Given this list of marker genes OR4K17, OR52E1, OR2F2, OR51V1, OR56B4, OR8B8, OR5D13, OR8D1, OR13C7, OR2H1, OR2L13, OR2B11, OR52E8, OR5J2, OR2F1, OR11H7, OR1I1 (NCBI Gene Id 56657), OR52N5, OR8U1, OR5K3, OR4N2, OR1M1, OR8G1, OR4Q2, OR1D4, OR10R2 (NCBI Gene Id 79506), OR2A42, OR1B1, OR6C74, OR4F5, OR5A1, OR5F1, OR2T27, OR6B1, OR5K2, OR9I1, OR6B2, OR2G3, OR10V1, OR51D1, OR51A4, OR56A3, OR10Z1, OR6M1 (NCBI Gene Id 79548), OR2AG1, OR4A15, OR1F1, OR10AG1, OR2T29, OR14L1, OR2T10, OR52K2, OR1Q1, OR11H1, OR2T1, OR4X2, OR4D1, OR6C68, OR56B2P, OR8I2, OR10A2, OR1S2, OR6C1, OR8K1, OR2I1P, OR10W1, OR2AG2, OR10K1, OR10G6, OR8J3, OR4N5, OR5T3, OR1L6, OR4C45, OR4C5, OR10D3, OR8H3, OR51B4, OR5AS1, OR52N4, OR51L1, OR56B1, OR1S1, OR7D4, OR10G4, OR52N2, OR6N2, OR2AJ1, OR51G1 (olfactory receptor family 51 subfamily G member 1), OR2AE1, OR2T11, OR2A5, OR10J5, OR5A2, OR8B12, OR13C2, OR6J1, OR8A1 (olfactory receptor family 8 subfamily A member 1), OR4C12, OR4S1, OR6C65, OR4B1, OR5AR1, OR5M3, OR1K1, OR5V1, OR2T6, OR51M1, OR1J1, OR9Q2, OR14I1, OR11L1, OR5H2, OR2A12, OR1L4, OR6A2, OR4K15, OR4L1, OR4F3, OR10X1, OR7G2, OR3A1, OR8B4, OR10G2, OR5AP2, OR56A5, OR5K4, OR8H1, OR9G9, OR51I2 (olfactory receptor family 51 subfamily I member 2), OR4C15, OR5T2, OR51S1, OR10AD1, OR2M3, OR4A47, OR2AK2, OR4K14, OR10H3, OR4D10, OR5C1, OR11H6, OR13C6P, OR52K1, OR51A2, OR1A1, OR4M2B, OR1N1, OR9A4, OR9A1P, OR2G6, OR4A8, OR13C5, OR7G1, OR4K3 (olfactory receptor family 4 subfamily K member 3 (gene/pseudogene)), OR1D5, OR52B2, OR5L1, OR6V1, OR11H4, OR1E1, OR8B3, OR4C11, OR52J3 (olfactory receptor family 52 subfamily J member 3), OR13F1, OR2T12, OR1F2P, OR5AN1, OR7A2P, OR9G4, OR14J1, OR9A2, OR10K2, OR11H12, OR5L2, OR51B2, OR2B6, OR1E3, OR2B8P, OR2AT4, OR5W2, OR5H14, OR2J1, OR51B6, OR8J1, OR4F16, OR4D2, OR2L8, OR2T35, OR56A4, OR8G2P, OR6S1, OR8S1, OR14A16 (NCBI Gene Id 81455), OR10J6P, OR1J2, OR8K3, OR4A5, OR10A4, OR6C2, OR10D4P, OR5P2, OR51G2, OR1A2, OR2Z1, OR10S1, OR10G8, OR6K3, OR52A5 (NCBI Gene Id 390054), OR5M11, OR52L2P, OR10C1, OR2K2, OR5AU1, OR52M1, OR52A1, OR5H6, OR52W1, OR14A2, OR5M1, OR51F2, OR2C3, OR6K6, OR7C1, OR10Q1, OR4K13, OR5T1, OR52I2, OR1G1 (olfactory receptor family 1 subfamily G member 1), OR11G2, OR6N1, OR51A7, OR8H2, OR51H1, OR5AC1, OR51E1, OR8D4, OR2W1, OR4S2, OR2M2, OR6P1, OR2A25, OR52P1, OR51B5, OR4C46, OR2A4, OR4C6, OR5B2, OR2H2 (NCBI Gene Id 7932), OR4N4, OR6Y1, OR5D18, OR14K1, OR5B12, OR13C8, OR4C16 (olfactory receptor family 4 subfamily C member 16), OR6C70, OR5P3, OR2G2, OR52E5, OR1L8, OR5B3, OR51J1, OR7G3, OR2T8, OR10AC1, OR8U3, OR4D9, OR8D2, OR4K2, OR5M8, OR7A17, OR6C75, OR4D6 (olfactory receptor family 4 subfamily D member 6), OR5AK2, OR52H1 (olfactory receptor family 52 subfamily H member 1), OR2W3, OR2J3, OR8U9, OR52N1, OR10P1, OR3A3, OR10J4, OR2M4, OR51T1 (olfactory receptor family 51 subfamily T member 1), OR4F6 (NCBI Gene Id 81403), OR52D1, OR2W5P (olfactory receptor family 2 subfamily W member 5 pseudogene), OR13H1, OR56A1, OR2A7, OR2T3, OR4K5, OR7A5 (olfactory receptor family 7 subfamily A member 5), OR12D1, OR12D2, OR10J3, OR4P4, OR4F17, OR6C76, GPR148, OR7C2, OR4E2, OR5G3, OR10H2, OR52B6, OR6C3, OR4A4P, OR2L3, OR2T2, OR4F4, OR2W6P, OR5M10, OR1L1, OR6C4, OR2A14, OR3A2, OR4M1, OR2AP1, OR4D11, OR52E2, OR1D2, OR4M2, OR1N2, OR4F15, OR51Q1, OR5AC2, OR2V1, OR5H8, OR4C13, OR2D3, OR12D3, OR2J2, OR13D1, OR4D5, OR2T4, OR4F29, OR5B21, OR10A3, OR5B17, OR1F12P, OR9G1, OR8G5, OR1J4, OR13C9, OR6X1, OR2M5, OR2T33, OR7A10, OR51F1, OR9Q1, OR52I1, OR4A16, OR10A5, OR14C36, OR13C4, OR8K5, OR1C1, OR1P1, OR10A6, OR13A1, OR5BS1P, OR52L1, OR6K2 (NCBI Gene Id 81448), OR10H1, OR11A1, OR10H4, OR2L5, OR1L3, OR52E4, OR10T2, OR2C1, OR2A2 (NCBI Gene Id 81393), OR4E1, OR2B2, OR2S2, OR2D2, OR5I1, OR2A1, OR4C3, OR2B3, OR7D2, OR5M9, OR10H5, OR8B2, OR13C3, OR8U8, OR51E2, OR52R1, OR1E2, OR2T34, OR10G3 (olfactory receptor family 10 subfamily G member 3), OR2M7, OR6T1, OR10G9 (NCBI Gene Id 81351), OR6C6, OR51I1, OR6F1, OR11H2, OR5H15, OR5H1, OR5AL1, OR9K2, OR52E6, OR5D16, OR2L2, OR10J1, OR52Z1P, OR10A7, OR52A4P, OR5AK3P (NCBI Gene Id 81228), OR8J2, OR2Y1 (NCBI Gene Id 79489), OR6Q1 (olfactory receptor family 6 subfamily Q member 1), OR2V2, OR4K1, OR7E24, OR4X1, OR6B3, OR8G3P, OR13G1, OR51C1P, OR5D14, OR4F21, OR13J1, OR52B4 (olfactory receptor family 52 subfamily B member 4), OR2T7, OR4Q3, OR5K1, OR2T5 (NCBI Gene Id 81460), OR10G7, here is a description of the gene set: studied in species Homo sapiens Combining with an odorant and transmitting the signal from one side of the membrane to the other to initiate a change in cell activity in response to detection of smell. Human Gene Set: GOMF_OLFACTORY_RECEPTOR_ACTIVITY